Given this list of marker genes Pkd1, Hes5, Hes1, Wnt9b, Pax8, Cxcr2, Sox9, Pax2, Wnt4, Lgr4, Sox8, here is a description of the gene set: Mouse Gene Set: GOBP_METANEPHRIC_TUBULE_MORPHOGENESIS The process in which the anatomical structures of a metanephric tubule are generated and organized from an epithelium. A metanephric tubule is an epithelial tube that is part of the metanephros. species: Mus musculus